Given this list of marker genes AKAP4 (A-kinase anchoring protein 4), GRK4, BRDT, RIBC2, CYLC2, MLF1, PLAAT1, SPATA6, MS4A5, HSPA1L, DDX25, IZUMO4, OAZ3 (ornithine decarboxylase antizyme 3), TPTE, IL13RA2, TEX14, ZC3H14, PHF7, PGK2, ZC2HC1C, FNDC11, SPACA9, GSG1, IFT88, CABYR, PRM2, GAPDHS, TSSK2, CCIN, MROH7, REXO5, ACRV1, DPEP3, YBX2, KCNK4, SLC6A16, TCFL5, AKAP3, UBQLN3, PIAS2, CCNA1, IFT122, NME5, CEP112, SHCBP1L, GSTM3, GID4, PDHA2, SPAG6, ACR, CRISP2, TNP1, CCDC70, ZPBP, HSPA4L, ACTL7B, KDM4D, ADAM29, FNDC8, ACSBG2, ACTL7A, ADAM2, CLPB, ANKRD7, RBMXL2, SPA17, TUBA3C, ODF1, SOX5, CCT6B, IQCE, H2AP, TRIM13, LRRC36, DKKL1, TCP11, DNALI1, PRM1, CSPG4 (chondroitin sulfate proteoglycan 4), APH1B, ZNF473, FSCN3, ODF2, LDHC, DDX4, ROPN1, GK2, here is a description of the gene set: Human Gene Set: GNF2_MLF1 Neighborhood of MLF1 myeloid leukemia factor 1 in the GNF2 expression compendium Neighborhood of MLF1 studied in species Homo sapiens